Given this list of marker genes ERBIN, CASQ2, TAPT1, ROCK2, DAZL, IL20RA, EHF, FAM13A, DSC3, DIS3L2, TRIM66, HNRNPK, EPHA5, FBXL3, CCL28, TBC1D23, IBTK (inhibitor of Bruton tyrosine kinase), MAP9, TWF1, FANCC, PDCL, CHL1, SHISA2, TTC9C, LGI2, RAB7A, APLP2, GOLIM4, SCG3, CARF, MAPDA, NRG1, ABHD6, KLHDC1, CXXC4, DLAT, NUDCD2, EXOC5, GRAMD2B, GDI2, ZNF45, RSPRY1, EPHA7, MED13L, CXCL9, DAZ4, GPR180, FAM171B, BMP2, ACADSB, SIPA1L2, BCAP29, MAP3K20, MAPK6, SOS2 (SOS Ras/Rho guanine nucleotide exchange factor 2), COMMD2, GNPDA1, HEXIM1, ARL6IP6, SGCE, PHF12, DAZ3, FGFR2, SCYL1, TTC14, BMPR2, CASK, FBXW7, MS4A6A, RAB23, DBT, ZBED2, XIAP, CLHC1, TMEM183A, NLGN1, DAZ2, SH3D19, NRBF2, MSI2, FCHSD2, YWHAB, HSF2, HYCC2, CAMLG, ARSJ, NMD3, RBPMS, WDSUB1, IKZF4, ASXL2, FAM174A, PDLIM5, ZFPM2, CIMAP1A, ROBO1, C5orf24, WHAMM, CDC40, DAZ1, TFDP2, CNOT6L, SRI, WT1, RO60, ENG, KIF13A, SPATS2L, TRA2A, COMMD6, VAMP3, NRP1, SYAP1, RC3H1, AP5M1, FBXL4, DIPK2A, GRIA4 (NCBI Gene Id 2893), ZKSCAN7, NDFIP2, CCDC6, SERPINE2, RGS18, HMMR, ZFX, FYCO1, AAK1, PLCXD3, MEIKIN, ANXA5, TMEM135, MYL12A, PTPMT1, MUC15, CNTROB, SESN3, ABCD4, MINDY2, RAP2C, ZDHHC17, PPP4R3B (protein phosphatase 4 regulatory subunit 3B), here is a description of the gene set: from publication Chen Y, Wang X (PMID 31504780) studied in species Homo sapiens Genes predicted to be targets of miRBase v22 microRNA hsa-miR-3920 in miRDB v6.0 with MirTarget v4 prediction scores > 80 (high confidence targets). Human Gene Set: MIR3920